The following is a description of a gene set: species: Homo sapiens Human Gene Set: GOBP_POSITIVE_REGULATION_OF_MYELINATION Any process that activates or increases the frequency, rate or extent of the formation of a myelin sheath around nerve axons., and this is the list of marker genes: DICER1, ITGAX, ZNF488, TPPP, WASF3, MYRF, S100B, PARD3, IGF1, CDK18, NCMAP, CST7, EGR2, TENM4, MAG, NRDC, RNF10, SOX10, QKI, TNFRSF1B, DAG1